Given this list of marker genes MDH2, SDHAF2, CYP24A1, CDKN2B, SDHD, CDC73, TBCE, GNAS-AS1, SEC61A1, PTH, TRPV6, CLDN16, CYP3A4, SLC34A3, RET, FH (fumarate hydratase), TMEM127, KL, PDE4D, OCRL, SDHA, STX16, KIF1B, VHL, CMPK2, VDR, GNAS, RNU4ATAC, DLST, MIR140, UMOD, SLC25A11, NF1, CDKN2C, CYP27B1, SAMD9, PHEX, MEN1, CYP2R1, GCM2, PRKAR1A, SDHB, FAM20A, TBX1, CDKN1A (cyclin dependent kinase inhibitor 1A), CASR, SOST, SLC34A1, MAX (NCBI Gene Id 4149), CLDN19, AIRE, CDKN1B, ADORA2A, SDHC, here is a description of the gene set: Human Gene Set: HP_ABNORMAL_CIRCULATING_CALCIUM_PHOSPHATE_REGULATING_HORMONE_CONCENTRATION Any deviation from the normal concentration in the blood circulation of a hormone that is involved in the regulation of phosphate and calcium. species: Homo sapiens Abnormal circulating calcium-phosphate regulating hormone concentration